Given this list of marker genes Srsf2, Smc6, Cpsf6, Tardbp, Smc5, here is a description of the gene set: studied in species Mus musculus Mouse Gene Set: GOCC_INTERCHROMATIN_GRANULE A class of nuclear body measuring 20-25 nm in diameter and distributed throughout the interchromatin space, linked together by thin fibrils. They are believed to be storage centers for various snRNAs, snRNPs, serine/arginine-rich proteins and RNA polymerase II. A typical mammalian cell contains 25-50 clusters of interchromatin granules. Interchromatin granule clusters do not contain the heterogeneous nuclear RNA-binding proteins (hnRNPs).